The following is a description of a gene set: Mouse Gene Set: MIR_6541 studied in species Mus musculus Genes predicted to be targets of miRBase v22 microRNA mmu_miR_6541 in miRDB v6.0 with MirTarget v4 prediction scores > 80 (high confidence targets). from publication Chen Y, Wang X (PMID 31504780), and this is the list of marker genes: Cdin1, Fchsd1, Pthlh (NCBI Gene Id 19227), Zmat3, Pank3 (NCBI Gene Id 211347), Dusp18, Zfp174, Cdkn1b, Garre1, Kif13a, Wdfy3, Tmod2, Tmem248, Esco2, Rftn1, E2f5, Maf, Rbm27, Zfand5, Synpo, Osbpl6, Ahcyl2, Kctd6 (NCBI Gene Id 71393, potassium channel tetramerisation domain containing 6), Kras, Sorbs2, Vmn1r32, Sf3b2, Mllt10, Gpr149, Mtf2, Frem2, Igsf1, Usp32, Zfp59, Defb20, Rad21, Irx4, Gnpda2, Zfp91, Lamp1, Cacna1e, Gopc, Aak1, Pom121 (NCBI Gene Id 97245), Pou3f2, Rnf146, Ms4a1, Jhy, Mob4, Sprr2k, Lrch3, Eif4g1, Scn3a, Mtcl1, Eloc, B3galt5, Cntn4, Brd8, Ssr1, Syngr2, Ndst3, Utrn, Hint1, Rusc1, Cul4b, Gins3, Hook1, Cnksr2, Unkl, Fndc3b, Gatad2b (NCBI Gene Id 404569), Brpf3, Cks2, Rb1cc1, Ccar1, Mideas, Etnppl, AA467197, Ss18l1, Ppp4r4 (protein phosphatase 4, regulatory subunit 4), Fgf12, Arid4b, Grsf1, Dnajb5, Vcf1, Cracdl, Plag1, Prx, Zfp715, Rimbp3 (NCBI Gene Id 385766), Scn2a, Tmem250, Fgd4, Tm9sf4, Eif4h, Arl4d, Zfp688, Dpf2, Cct8, Cers4, Mip, Klf12, Eif4g2, Cog5, Marchf8, Oxsm, F2rl1, Ythdc2, Cast, Gjb2, Yy1, Nacc2